The following is a description of a gene set: species: Mus musculus Mouse Gene Set: GOBP_CILIUM_DISASSEMBLY A cellular process that results in the breakdown of a cilium., and this is the list of marker genes: Hdac6, Aurka, Nedd9, Map4, Kif19a, Rrp7a